Given this list of marker genes Dna2, Bard1, Khdc3 (NCBI Gene Id 66991), Blm, Fam111a, Bod1l, Asf1a, Setmar, Etaa1, Fbh1, Primpol, Rad50, Parp1, Smarcal1, Rfwd3, Rtel1, Eme1, Dynll1, Brca1, Mms22l, Polg, Tipin, Zfp365, Donson, Cenps, Eme2, Atr, Polq, Pcna, Ooep, Tonsl (tonsoku-like, DNA repair protein), Zranb3, Timeless, Nucks1, Recql, Mre11a, Wrn, Carm1, Atrx, Pold1, Cdk9, Gen1 (GEN1, Holliday junction 5' flap endonuclease), Traip, Pole, Ddx11, Nbn, Cenpx, Fancm (NCBI Gene Id 52599), Rbbp8, Brca2, Samhd1, Rad51, Exo1, Exd2, Mcm9, Mus81, here is a description of the gene set: studied in species Mus musculus A DNA metabolic process that prevents or corrects errors to ensure that DNA is replicated accurately. Errors can be corrected either by intrinsic DNA polymerase proofreading activity or via mismatch repair. Mouse Gene Set: GOBP_DNA_TEMPLATED_DNA_REPLICATION_MAINTENANCE_OF_FIDELITY